The following is a description of a gene set: NADPH-cytochrome P450 reductase (CPR) is an essential component for the function of many enzymes, including microsomal cytochrome P450 (P450) monooxygenases and heme oxygenases. In liver-Cpr-null (with liver-specific Cpr deletion) and Cpr-low (with reduced CPR expression in all organs examined) mouse models, a reduced serum cholesterol level and an induction of hepatic P450s were observed, whereas hepatomegaly and fatty liver were only observed in the liver-Cpr-null model. Our goal was to identify hepatic gene expression changes related to these phenotypes. Cpr-lox mice (with a floxed Cpr gene and normal CPR expression) were used as the control. Through microarray analysis, we identified many genes that were differentially expressed among the three groups of mice. We also recognized the 12 gene ontology terms that contained the most significantly changed gene expression in at least one of the two mouse models. We further uncovered potential mechanisms, such as an increased activation of constitutive androstane receptor and a decreased activation of peroxisomal proliferator-activated receptor-alpha by precursors of cholesterol biosynthesis, that underlie common changes (e.g. induction of multiple P450s and suppression of genes for fatty acid metabolism) in response to CPR loss in the two mouse models. Additionally, we observed model-specific gene expression changes, such as the induction of a fatty-acid translocase (Cd36 antigen) and the suppression of carnitine O-palmitoyltransferase 1 (Cpt1a) and acyl-CoA synthetase long chain family member 1 (Acsl1), that are potentially responsible for the severe hepatic lipidosis and an altered fatty acid profile observed in liver-Cpr-null mice. Human Gene Set: WENG_POR_TARGETS_GLOBAL_UP Genes up-regulated in liver from transgenic mice with reduced expression of POR in all tissues. studied in species Mus musculus from publication Weng Y, DiRusso CC, Reilly AA, Black PN, Ding X (PMID 16006652), and this is the list of marker genes: AQP8, CYP7A1, FDPS, CES2 (carboxylesterase 2), CYP2B6, CYP2C18, ETHE1, MSMO1, CYB5B, GSTA2, HMGCS1, SQLE, GSTM1, GSTM5, GCK, TCEA3, CYP51A1, IDI1, SCD, DHCR7